Given this list of marker genes SLC44A1, STRA6, FLVCR1, FLVCR2, SLC44A2, ABCA4, MFSD10, RBP4, here is a description of the gene set: Human Gene Set: GOMF_ALCOHOL_TRANSMEMBRANE_TRANSPORTER_ACTIVITY Enables the transfer of an alcohol from one side of a membrane to the other. An alcohol is any carbon compound that contains a hydroxyl group. species: Homo sapiens